The following is a description of a gene set: from publication Cao J, O'Day DR, Pliner HA, Kingsley PD, Deng M, Daza RM, Zager MA, Aldinger KA, Blecher-Gonen R, Zhang F, Spielmann M, Palis J, Doherty D, Steemers FJ, Glass IA, Trapnell C, Shendure J (PMID 33184181) Human Gene Set: DESCARTES_MAIN_FETAL_MESANGIAL_CELLS The gene expression program underlying the specification of human cell types is of fundamental interest. The study authors generated human cell atlases of gene expression and chromatin accessibility in fetal tissues. For gene expression, the study authors applied three-level combinatorial indexing to >110 samples representing 15 organs, ultimately profiling ~4 million single cells. The study authors leveraged the literature and other atlases to identify and annotate hundreds of cell types and subtypes, both within and across tissues. Our analyses focused on organ-specific specializations of broadly distributed cell types (such as blood, endothelial, and epithelial), sites of fetal erythropoiesis (which notably included the adrenal gland), and integration with mouse developmental atlases (such as conserved specification of blood cells). These data represent a rich resource for the exploration of in vivo human gene expression in diverse tissues and cell types. species: Homo sapiens Marker genes curated from the annotated cluster as represented in the Descartes Human Gene Expression During Development database., and this is the list of marker genes: TMTC1, DACT3-AS1, TEX15, LINC01842, GRASLND, TARID, FLRT2, LINC02737, KIF26B, REN, MOXD1, GNA14, NR2F2-AS1 (NCBI Gene Id 650193), LINC01797, TRERF1, CLDN11, PTK7, ALX1, LINC00924, RNU6ATAC31P, SULT1E1, PRICKLE1, RN7SL832P, FOXL1, METTL24, HOXD10, CCN4